Given this list of marker genes Dock2, Car6, Mfap4, Rpl39l, Ccn5, Stc2, Scd1, Mafb, Rab3il1, Zfp781b, Fli1, Rbp1, 1810014B01Rik, Lyl1, Insig1, Slc37a2, Mcf2l, Fam111a, AW551984, Lss, Otulinl, Ptpn18, Phip, Pdgfra, Hey1, Nnmt, Nr4a2, Acan, AI467606, Foxg1, Ahr, Celf2, Aldh1a3, here is a description of the gene set: from publication Plasari G, Calabrese A, Dusserre Y, Gronostajski RM, McNair A, Michalik L, Mermod N (PMID 19752192) Genes down-regulated after 10 h of TGFB1 stimulation in MEF cells (embryonic fibroblast) with NFIC knockout vs wild type MEFs. Mouse Gene Set: PLASARI_TGFB1_SIGNALING_VIA_NFIC_10HR_DN Transforming growth factor beta (TGF-beta) and platelet-derived growth factor A (PDGFAlpha) play a central role in tissue morphogenesis and repair, but their interplay remain poorly understood. The nuclear factor I C (NFI-C) transcription factor has been implicated in TGF-beta signaling, extracellular matrix deposition, and skin appendage pathologies, but a potential role in skin morphogenesis or healing had not been assessed. To evaluate this possibility, we performed a global gene expression analysis in NFI-C(-/-) and wild-type embryonic primary murine fibroblasts. This indicated that NFI-C acts mostly to repress gene expression in response to TGF-beta1. Misregulated genes were prominently overrepresented by regulators of connective tissue inflammation and repair. In vivo skin healing revealed a faster inflammatory stage and wound closure in NFI-C(-/-) mice. Expression of PDGFA and PDGF-receptor alpha were increased in wounds of NFI-C(-/-) mice, explaining the early recruitment of macrophages and fibroblasts. Differentiation of fibroblasts to contractile myofibroblasts was also elevated, providing a rationale for faster wound closure. Taken together with the role of TGF-beta in myofibroblast differentiation, our results imply a central role of NFI-C in the interplay of the two signaling pathways and in regulation of the progression of tissue regeneration. studied in species Mus musculus